The following is a description of a gene set: Genes containing one or more binding sites for (SALL4) in their promoter regions (TSS -1000,+100 bp) as identified by GTRD version 20.06 ChIP-seq harmonization. species: Homo sapiens Human Gene Set: SALL4_TARGET_GENES from publication Yevshin I, Sharipov R, Kolmykov S, Kondrakhin Y, Kolpakov F (PMID 30445619), and this is the list of marker genes: ZNF419, C1orf74, ZNF7, KPNA5, DEDD, KAT7, RAB35, ZFP91, CDK12, LRRTM4-AS1, GATAD2A, H2AZ2-DT, LINC03017, POLDIP3, SUMF1, POU2F1, UBE2Q1, SLC17A7, ZSWIM3, GABARAP, STARD5, MXD1 (NCBI Gene Id 4084), SIRT4, TRAPPC9, ZHX1-C8orf76, INTS13, HMGCR, RSBN1, TMEM30A, HDAC4-AS1, SETD5, PAIP2B, CASC3, MRPL14, SSBL4P, MGMT, SLC37A4, RMST, EFCAB6, PRADC1, R3HDM2-DT, CAMK2G (calcium/calmodulin dependent protein kinase II gamma), PDE2A-AS1, EFCAB11, DPYSL3, STRIP1 (striatin interacting protein 1), HSPA8, MORF4L2, ZNF664, ODC1-DT, SMDT1, CENPL, OTX2, SARAF, EXD1, TNFAIP1, DDX39A, ANKZF1, HEXIM2-AS1, PAFAH2, ITPRID1, CRYZL1, UBIAD1, DHX32, ABCF3, KAZALD1, FBXO3 (NCBI Gene Id 26273), PARP1, TMEM63B, LRP6, TEPSIN, ZNF687, HEY2-AS1, ANKRD16, SERTAD3-AS1, PMS2, PRPF31, OCA2, LACTB2, SKA3, RPS6KA5, LATS1, ANK3, CER1, NUBP2, ZNF280D, ACADSB, KDM4A, BTBD10, RABEP1, MIR4479, IRGQ, UHRF2, TNRC6B, ABCB8, R3HDM2, FAAP24, ZNF277, CHMP4B, ALDH6A1, CCDC86, PUF60, LRRTM3, RNF5, KDM4B, ZDHHC14, METTL13, KCTD13, ZNF8, G3BP1, STKLD1, ATOH1, TRMT1L, VKORC1L1, DUS3L, DEDD2, AK2, TMEM104, AHCYL2, PCGF3, MAU2, PRDX1, COTL1, TRIM22, STARD9, UBE2I (NCBI Gene Id 7329), TAOK3, HIF1A, MRPL45P2, HBS1L, CCT8, FHL1P1, CFAP20, GNL1, TCAF1, HSPD1, OGT, DCLK1, TRIP12, ZW10, PAXIP1-AS2, CAPZA2, DNAJB5, RHOF, SLC25A26, RPL10A, RPS11, MIR933, ZNF141, GASK1B-AS1, ZFR2, CNOT1, ANKRD30A, SNRNP70, ELL2, PIERCE2, TIPARP, MVD, CYP1B1-AS1, CYP51A1, LARP4, SAMD4A, STRN, USP2, KMT2A, CCT7, PPFIA3, DRC3, LIN37, UFSP1, ZNF808, CYB5AP2, PDE12, TTC41P, YIF1B, ZNF77, ATG9A, FGFR1OP2, PRR3, MIR3681HG, BRD2, TMEM14B-DT, C2orf42, RPLP0, DNAJC11, PFKFB4, CARNMT1, GPBP1, AGPAT1, ENPP4, HPAT5, MIR320C1, ARID2, ATF3, GPR108, CENPJ, FAM220A, ATP6V1D, SLC15A2, ALKBH7, GATB, TRAF3IP1, SUPT5H, EZR, CNPY3, COPB2-DT, ZNF337, ZNF518A, BANCR, RTF1, CLP1, TCF3, MGRN1, HINFP, CNP, MFF, GATAD2B, MRPL37, SBDSP1, CACTIN, AZI2, EPHA7, ATP11B-DT, STX1A, STK19, PPP1R12B, SIRT2, GGA3, MOBP, ENSG00000265055, PHLPP1, SNORD26, CCSER2, AASS, RPS6KB1, CTNNB1 (catenin beta 1), TRNAU1AP, NCOA4, BUD23, FAM98A, TOB1-AS1, VIRMA-DT, DET1, OSBP, SPSB3, NRDE2, ENSG00000256969, C8orf88, HELB, ISOC2, RPEP1, MYO1B, CDH13-AS2, FBXO36, RPH3A, TRIB1, PGAM1, ERI1, AGBL5, TOLLIP-DT, AJUBA-DT, ACOT13, LINC02511, NR3C2, RNU5E-6P, MYO10, FANCA, RPL35AP10, RGL1, ENSG00000255647, SLC39A7, ZFP14, INTS4, KLHL28, RPL10P15, ENSG00000241525 (novel transcript, antisense to C17orf97), ATXN2-AS, ABCC5, GRPEL1, CDC42, MTHFD2P1, PIAS4, XRCC3, PPP5C, LINC02233, PGM2L1, RPS26, SUGP1 (SURP and G-patch domain containing 1), TRIM71, CHRAC1, KHDRBS1, CHAF1A, POLA2, CEMP1, PSIP1, ISCU, ATPAF2, GASK1B, RNVU1-22, FAM136A, COX11 (NCBI Gene Id 1354), MIGA2, IQCD, KBTBD6, CBX1, GBA1LP, SERTAD2, VWA8, STXBP4, EHBP1, STYX, ZBTB7A, TENM2, FGFRL1, EDRF1 (erythroid differentiation regulatory factor 1), FOXN2, DGLUCY, PPRC1, CPNE3, KREMEN1, BAG1, SLFN12, PLXNC1, SEC24C, ZZZ3, EZH1, TSC1, SCAF11, RPS7P3, PARP10, GRB2, PPP2R5B, LINC00467 (long intergenic non-protein coding RNA 467), TMEM30A-DT, SERPINB9P1, BACH2, OSER1, C2CD2, KDM2A, CDKL3, RNF181, LAMTOR2, POT1-AS1, ENSG00000236106, LINC02614, EIF5B, PUM1, AP2S1, COPG1, YJU2, CCAR2, MEF2A, PEMT, DZANK1, SRSF10, ATXN1L, SLC15A4, DCAF16, HNRNPA3P8, CALD1 (NCBI Gene Id 800), DCAF13, CHTOP, TASOR2, OSER1-DT, HEATR5B, MLLT1, PAN3-AS1, TATDN3, INPP5F, STX18-AS1, RPL13AP26, METTL15, CCDC174, BCKDHB, LINC01551, ZNF25, BNIP3, NPM1, ATF2, SMAD3, PAXBP1, PLEKHB2, UBE2C, FDPS, STIP1, SMIM10L2B, GMPPA, PPP1R11, DOCK4, CDC16, ANKRD11, TMEM209, PAOX, RPL27, CEP295, KHK, LINC01508, UBB, EEF1A1, ZHX1, LINC01719, DNAJC17, CCDC88C, ACVR1, PAN3, PPM1K-DT, TNKS1BP1, GOT2, ZMYND8, NAMPT, LSS, CIAO2A, ZNF292, AGFG2, ZNF689, RBM4B, C4orf46, MADCAM1, ABI2, STYXL1, WDR36, ATP5MC1, WDR81, HSPE1-MOB4, XRCC2, TMEM60, IL23A, MT-CO3, IFT20, FILIP1, ZNF692, TMEM160, ENSG00000259704, TAX1BP3, COPB2, H2BC14, CEP350, PRR13, PCED1B, HSPB6, SHARPIN, PRPF39-DT, KIF18A, ACTN4, TASOR (NCBI Gene Id 51687), TUFM, USP2-AS1, NAT9, CENPX, CHCHD3, SEC31A, PPP2R5E, RAB4B, CYP2AC1P, RBPJ, TMEM143, ENSG00000187186, ARFGAP3, SLC11A2, SNX12, ZNF224, KLF6, TMED7-TICAM2, SLC39A3, WDR20, HMGCS1, ZNF112, EMG1, PJA2, AFTPH-DT, MEIS2, TNC (tenascin C), TFAP2A, CDK5, CHN2, NRL, RPIA, USP37, NANP, MALAT1, KCTD10, ABHD11, N6AMT1, UNC79, FOXA3, RPL21P112, RANBP2, SEPTIN2, TCFL5, ACOX3, CIAO1, TLE6, PCMTD1, ZNF285, ORMDL3, SKIC3, WIPI2, RAD51AP2, RAB4A, MOV10, DHX40, NSA2P4, SYMPK, EIF2AK3-DT, TMCO1-AS1 (TMCO1 antisense RNA 1), GSPT2, FAM230G, PDE6D, BCAS3, RPLP2P1, FERMT2, ITSN1, ZNF318, CCDC88C-DT, SLC19A2, GMCL1, GTF3C2-AS2, BANP, MMUT, TMED7, GABPB1-AS1, LRP3, TAS2R14, RANBP3, MIR3688-2, CFAP119, TIPARP-AS1, EBNA1BP2, PCAT6, ENSG00000233230, CAMTA1, SNORD25, UTP11, PPWD1, NME1-NME2, C6orf89 (NCBI Gene Id 221477), FBXO46, CRLS1, CDC37L1-DT, NOL7, RAB5C, SLC7A6OS (solute carrier family 7 member 6 opposite strand), KCTD9, FZR1, PSMA3-AS1, PROSER3, ULK1, IFT81, HDGF, USP30, CERS5, HUS1, KYAT3, ARL3, RAI14, CANX, SSNA1, LEPR, TMEM38A, MTMR12, LIAT1, MACROD2, ZSCAN22, KHSRP, ITGA9-AS1, LRRC27, LINC00471, LSG1 (large 60S subunit nuclear export GTPase 1), GTF2IP20, MAN1B1, RBSN, DDI2, PSMD2, RBL1, IVD, TICRR, FH, ZMIZ1-AS1, TXNDC9, LARP7, GID8, TMEM127, TUBB4B, SPG7, KDM5C, ZSWIM6, ZMIZ1, TSEN54, HSP90AA1, DOP1B (NCBI Gene Id 9980), MORC2, ENSG00000232876, LAMB1, PCYOX1, PPP2R3A, KCTD21-AS1, TBC1D9, SLC4A2, RBX1, TC2N, HSPBAP1, FAM86JP, ENSG00000275740, SUMF2, PGAP4, WIPI1, NSL1, PPARD (NCBI Gene Id 5467), MCMBP, POLR3G, PALS2, SEL1L, RACGAP1, HDLBP, UFD1-AS1, MT-TP, RANBP6, ZNF451, ARHGEF12, CFAP251, TMEM70, WAPL-DT, FDFT1, GOLGA7 (golgin A7), LINC01275, POLR2E, RAB40B, EIF2B3, TUBGCP5, USO1, EFHC1, ZNF888 (NCBI Gene Id 388559), EXOC5, NDUFV1, LIX1, G3BP2, PSMD14-DT, MIR3180-5, STX18, IBTK, RANBP1, CCDC61, NQO2-AS1, SECISBP2, STAP2, VPS26A, RPL4, NAPA, INO80B-WBP1, GNAI2, CCDC77, MPV17L2, PSENEN, EML1, WDCP, FAM86KP, SLC22A31 (solute carrier family 22 member 31), AMZ2, MED26, LMAN2, CIC, VAPB, LSM14B, NUDC, VMP1, CCNG1, DHX34, IKZF5, KBTBD6-DT, HMG20B, OSBPL1A, C1orf159, SPC25, TCF12, H2BC5, RNF32, NCOA2, PRXL2B, ACAD8, FBXL9P, SYPL1, C22orf39, PSMA3, SPRYD3, TJP2, PHF21A, REST, HSP90AB1, TENM3-AS1, HEXIM2, ELL, RNU6-92P, ZC3H6, PSAT1, ZNF286A-TBC1D26 (ZNF286A-TBC1D26 readthrough (NMD candidate)), SNORD27, PPFIA4, ENSG00000235979, CYB5RL, CLTC, BORCS8-MEF2B, RPL23AP11, PPP3CB-AS1, KMT5B, TSPAN31, WDPCP, PSME3IP1, PAM16, KLHDC3, NUP42, RXYLT1, DGKQ, ZNF83, GINM1, INTS9, H2BC16P, TNRC6C, TAOK2, SOX2-OT, FRG1CP, PPP1CA, STX2, TP53BP1, GABRB3, LTBP4, MDH2, WHAMM, DENR, NGLY1, RBM12B-DT (RBM12B divergent transcript), ZRANB2-DT, PCGF3-AS1, RBMXL1 (RBMX like 1), C15orf40, CHD9, PPP4R3B-DT, PITX2, AKT1S1, RBM27, ACLY, AP5M1, OXSM, ASPH, GPN3, RAP2A, SNHG1, GTF3C2 (NCBI Gene Id 2976), LINC00862, MKRN1, SPAG9, TXNDC11, SRRT, ELMO1, TRMT44, THYN1, ADPGK, SUMO1, RNF130, C1D, SAP30, CRTC1, FKBP3, TMCC1, MTG1, MIR548AW, EPCIP-AS1, PIM1, GSR, NUAK1, TMEM65, STK32C, PPM1N, EP400P1, OCIAD1, MRPL44, TESK2, GTF2I, PANK2-AS1, GRK4, PARD3, MIEF1, ZNF256, CBX5, UVSSA, ZNF337-AS1, PIPOX, AGBL5-AS1 (NCBI Gene Id 100874031), RPAP2P1 (RNA polymerase II associated protein 2 pseudogene 1), DNAJC30, PPCDC, TXNIP (thioredoxin interacting protein), RBPMS, FAM118A (family with sequence similarity 118 member A), GPRC5D-AS1, NDUFA5, UNC80, ABT1, CYP51A1-AS1, PAM, CHP1, PGP, INO80B, WDR47, HMBOX1, RPL36, ZNF225, EXOSC5, BCL7C, ALG8, PRR16, CENPF, AJUBA, RAB6A, DBP, ARID4A, LINC01484 (long intergenic non-protein coding RNA 1484), TOB2, ARMH4, RN7SKP175, FBXO3-DT, MPND, EIF3D, FGFR3, TAF5, MAN1B1-DT, USF3, ZCCHC24, TRAFD1, SELENOP, RXRB, XPO7, CANT1, E2F6, MIR3678, LURAP1L-AS1, BRPF1, PRKACA, SH3GL1, SNHG10, SACM1L, RIBC2, ORMDL2, ATP11B, PSMG4, CDC37L1, ZNF140, TBC1D10B, IMP3, SLCO5A1, PELI1, PTPN23-DT, SIL1, NFX1, PRMT5, RBM15B, STT3A, DHDDS, BORCS8, GM2A, RND2, ANK2, CASC2, NUP93, UBC, CDC5L, C19orf44, TDP2, LARS2-AS1, IST1, PTPRS, MIR9-2HG, UBR5, RBM15, MAD2L2 (NCBI Gene Id 10459), TMEM218, LINC01870, EXPH5, CMC1, SLC35F5, RNH1, SFXN2, RNF6, LINC01060, ATP5ME, TDRKH-AS1, FOXK1, LINC00674, ERICH2-DT, TUBA1B-AS1, WTAP, RPL24, EVI5L, SULF1, ZCCHC7, NKIRAS1, MORC3, SAP30-DT, MIR4757, TTLL7, RERGL (RERG like), FLAD1, TSSC4, CEP95, PLAC9, H2AC14, FBXL12, SF3B1, TIMM9, HSD11B1L, GOLGA5, RNF40, ZNF564, LACTB2-AS1, ZNF567, MBTPS1, RN7SKP38, ADGRL2, VPS51, RPL23AP33, ENSA (NCBI Gene Id 51620), ZNF888-AS1, MTNAP1, SORBS2, LINC01237, ZNF576, RSPRY1, ASXL1, TCEANC2, AFTPH, RIDA, NXN, FRYL, MT-TF, MIR7515HG, MFF-DT (NCBI Gene Id 654841), RRP12 (NCBI Gene Id 95039), DDA1, ERO1B, RNF32-DT, PJVK, WAPL, ZFYVE19, KDM5A, NUP107, EIF2AK3, UBE2B, TOR1AIP1, HOXC13, LRRC45, PPP6R1, DCAF1, DDX19B, LINC02453, TMC3-AS1, TMEM43, KLLN, TMEM41B, HIVEP1, ZWILCH, PTPN4, ETV5, ZKSCAN2, LINC01089, ELMO2 (engulfment and cell motility 2), CDC6, PPP4R4, VCP, TMEM94, TPCN1, VIRMA, PKM, NEMP1, NDEL1, CDH10, RNPC3, CDK5RAP3, ELF2, RANBP3-DT, RPS19, IPMK, POT1, ZNF280C, SRP19, IFT27, RAB4A-AS1, NOP14, CALM2, CCNF (cyclin F), NCAPG, NFKBIB, GLRX5, GLO1, EBAG9, CCNG2, SOX5, PPTC7, CHMP7, STK25, ZNF611, TDRKH, PDIA5, KIF2A, ETFDH, PKD1, FXR2, C19orf38, CENPK, DISC1, NQO2, MYH9, SEL1L2, JAG1, HAUS3, EFCAB6-DT, MT-TT, RFX2, PRR14L, SYNGR4, UBP1, NFE2L1, ZNF37A (NCBI Gene Id 7587), EIF2S2, GPBP1L1, HIRA, ERMN, GABPB1, TFCP2, RPS6KB2, PGBD4, TTI2, DXO, ANP32E, RNA5SP198, LARS1, APOLD1, ERRFI1, LINC02408 (long intergenic non-protein coding RNA 2408), RNGTT, UBR2, ZDHHC5, MCM3AP-AS1, KATNB1, OGA, ZNF37BP, DUSP6, TRIB1AL, AFP, HP1BP3, KCTD2, TMEM263-DT, ARRDC4, TMEM263, ERAP1, ACOT8, RELL1, MON2, CENPU, KIAA1586, WBP2, DLD, EVL, SPAG7, IREB2, OTX1, MT-RNR1, MIR5188, RSRP1, NUP153, ERGIC2, MIR6089, MIR302C, ZNF527, SEH1L, RAPGEF2, UTP3, NAA35 (N-alpha-acetyltransferase 35, NatC auxiliary subunit), TAF12, DNM2 (NCBI Gene Id 338330), VPS37D, ULK2, ENSG00000261335, EBLN3P, EIF2B1, DNPEP-AS1, CDK2AP2, BCL2L2-PABPN1, THAP9-AS1, ANKHD1, RRP1, CCDC88A, NEK3 (NIMA related kinase 3), ZC3H3, ATP5PD, RAD51B, H3-3B, EMC6, MAD1L1, LINC02570, SPRTN, CDKN2D, SEPTIN7P13 (NCBI Gene Id 84344), TENT5C-DT (TENT5C divergent transcript), PRKRIP1, VPS29, RNU4-2, SMC4, RNVU1-19, RSL24D1, EHD1, SLC8A1-AS1, FBXL19, HDAC9, DPPA4, RNF111, HNRNPC (NCBI Gene Id 3183), TMBIM6, INPP5A, SLC41A3 (solute carrier family 41 member 3), ZNF286A (zinc finger protein 286A), NOC3L, NME1, ENAH, POLG2, NAMPT-AS1, NCOA5, FRA10AC1, CENPQ (NCBI Gene Id 55166), SPRED1, PDE7A, VHL, COL18A1 (collagen type XVIII alpha 1 chain), RRM2B, OSBPL9, PAN2, SSR3, TMCC3, MIR302CHG, RINL, EMD, CITED4, IFT80, PPP1R16B, MYADM, SP5, FOXK2, KCTD13-DT, PRPF39, MRPL57, PACRG, RPL27A, TOM1L2, HDAC2-AS2, ODAD4, ZNF184, DLGAP1-AS2, HIBADH, EIF4A3, CCDC92, EPS15L1, DICER1, MIR1245B, PTTG1IP, BLOC1S5-TXNDC5 (BLOC1S5-TXNDC5 readthrough (NMD candidate)), PRKRA (NCBI Gene Id 94716), IFIT3, SCAF4, INO80D-AS1, PCCA, MRPL55, TEDC1, P4HB, CDIP1, XAB2, ACSL1, TXNRD2, TAF12-DT, CALCOCO1, TULP3, PTPN23, TMED1, RAB43, SRFBP1, PGRMC2, DDX27, NUMB, PKNOX1, RFX1, CCNB2, ANAPC5, LSM14A, BTF3, SURF4, HMG20A, ICMT-DT, ZNF335, ANP32A, RBM15-AS1, ATP5F1B, PHF12, TOMM40, SERTAD3, PNRC1 (NCBI Gene Id 10957), EPHA6, AKTIP, CEP83-DT, ZFYVE26, BMAL1, CAND1, QRICH1, MRPS16, TCERG1, ASB7, NUDCD1, MAGI1, SOX6, LINC02960, MIR638, ABHD5, FAF2, EIF4A2, SLC3A2, PPP3CB, MIR4470 (NCBI Gene Id 100616484), FAM135A, MIA3, MMD, TPM1, TMEM115, KHDC4, SLCO5A1-AS1, AARS1, DDX23 (NCBI Gene Id 9416), GBA1, MAZ, ARF1, SNRPC, ELP3 (NCBI Gene Id 55140), HESX1, ZNF567-DT, BSDC1, DAAM1, CTNND2, SPAST, TTC7B-AS1, ZNF687-AS1, FOXRED2, RMND1, ERRFI1-DT, AUTS2, SDR39U1, PA2G4, RN7SL810P, ARFIP1, PEAK1, EXOC8, TRMT2A, SEC1P, KLHL24, NEPRO, OIP5-AS1, PRDM10, PRMT7, MYO5C, CERT1, ZNF559-ZNF177, ZCWPW2, DCLRE1B, TBC1D15, NDUFAF8, MAP2K2, HNRNPDL, CNNM2, NPHP4, PLS1, LENG1, UBR5-DT, CCPG1, LINC02926, HNRNPL, RNU7-88P, RNU6-263P, SDE2, ODC1, BCL2L2, ERN1 (NCBI Gene Id 63433), MARS1, AP2M1, GFPT2 (glutamine-fructose-6-phosphate transaminase 2, NCBI Gene Id 9945), LRCH4, AK7, FAM76A, ZNF281, MTRFR, LYSMD1, AVPI1, MYPOP (Myb related transcription factor, partner of profilin), HLTF, HDAC4, FBH1, VCF1, B3GNTL1, ANKFY1, RCOR3, SMPD1, BBX, PNKD, BCO1, ACCS, XPO5, TTC21B, RSU1, KANSL2, PEX19, CD99P1, PNRC1-DT, MRPS31, CCNI, SP4, DLEU1, RAD9B, BCKDHA, ACTR3, KLF10, LRIG1, LINC02282, ARHGAP26, CUEDC2, RAB5B, CYRIB (NCBI Gene Id 51571), ESCO2, PHF23, THUMPD3-AS1, RMDN1, MRPL24 (NCBI Gene Id 79590), PEX16, MIR3190, ENY2, CBR3-AS1, ENOPH1, BRWD1, CCDC144NL-AS1, SRSF1, POLK, RBM42 (RNA binding motif protein 42), LINC01649, TRAM1, LDB2, SDHB, HDGFL2, SMIM14, ATXN2, MOB3A, KIAA0319L, GBF1, SRRM5, PUM2, SMG5, RAB4B-EGLN2, LINC01409, SND1, MYL5, LMBR1, SFI1, EIF5, H2BC6, PHIP, RIC8B, BCL2L1, NFATC2IP, ZNF692-DT, CALR3, FAM86DP, PPM1B, TRAV6, ZNF341-AS1, SNORA70, RNU6-173P, DDX5, SELENOK, HBP1, AAMP, MTHFD1, VRK3, ABCA7, CALM3, TOB1, PCBP2, ABLIM2, TECRP1, ZSCAN10, SH3BP2, PTEN, DNAJB12, MAFK, PIGF, CETN3, LETM1 (NCBI Gene Id 3954), LINC00838, ADCK5, PPP5D1P, BCL3, EML4, TIPIN, RNF43, ERCC6L2-AS1, DNLZ, PSMD5, MEPCE, THAP9, ABI1, SCAF1, SREBF2, KIZ, UBE2D3, GPC1, PCMTD1-DT, LIMD1-AS1, VPS8, HSBP1, CNKSR3, POGZ, OSR2, FMNL3, TFAP4, MDM4, NAV2, TMEM79, LRATD2, ZNF106, UGGT2, ARMH3, CALU, EGLN3, FRAT2, OBSL1, ZNF25-DT (NCBI Gene Id 105376499), ETV4, PDK1, TUBGCP3, SLC38A4-AS1, TGIF1, EIF3E, TTLL12, ZC3H14, RETREG3, CHST12, PEX10, EDRF1-DT, PDE2A, MICOS13, EIF4ENIF1, AP1G1, BLOC1S5, C19orf73, PRKN, NLK, FRMD5, UQCRC1, TMCO1, H2AZ2, AFG3L2, H2BC4, IZUMO4, PFKFB2, RPL15, ERCC6L2, SLC7A11, LINC02901 (long intergenic non-protein coding RNA 2901), OSBPL2, LRRTM4, PET100, CNOT9, ACTL6A, RMDN3, CDK4, IQGAP1, CDC42SE1 (CDC42 small effector 1), MTMR4, ANKHD1-DT, TCF19, RGS5, DARS2 (aspartyl-tRNA synthetase 2, mitochondrial), PHB2, AIRIM, NELFB, GPRC5B, LINC01013, ANAPC2, FAM117A, MDC1, KLHL26, LINC01124, CP, MIR3178, NOLC1, SH2B1, ZFP91-CNTF, CCHCR1, ZNF816-ZNF321P, NAPB, SMG1P3, MIR548AL, GPAA1, RAB3A, LSM4, ARMT1, PELP1-DT, MRTFA, TIAM2, UBQLN4, LAMTOR3, NPTN, PDE7A-DT, KANSL3, TCF4, FGFR2, ENSG00000272008, ZCCHC8, H2AC16, ASNS, SNHG16, SMNDC1, GNB2, MTND6P17, SP1, DICER1-AS1, RNF126, METTL2B, LMCD1-AS1 (NCBI Gene Id 401050), AP3S2, GFI1B, LRRC28, SYNPO2, SREBF1, SNX1, PRR11, ENSG00000206853, ZNF526, USP36, NUDT16-DT, SEC23IP, TMEM14B (NCBI Gene Id 81853), CLASP1 (cytoplasmic linker associated protein 1), AKAP11, PCNX3, BIRC5, LINC01320, FOXJ3 (forkhead box J3), PDP2, ZFYVE27, DCAF11, LIN52, TOLLIP, POLH, DNAJB5-DT, NCBP1, GOLT1B (NCBI Gene Id 51026), ZBTB20, RBM12B, PLD6, CT66, EMC7 (NCBI Gene Id 56851), TMEM69, GTPBP1, SLC49A4, SARNP, CAV1, TUBD1, PXN-AS1, KBTBD7, RAB1A, HEXIM1, SNAI3-AS1, FASTKD1, NCDN (NCBI Gene Id 23154), ZNF816, MSMO1, MARS2, STEAP2-AS1, USP3, ZFYVE21 (zinc finger FYVE-type containing 21), NIPA2, ZNF225-AS1, MIR22HG, MATR3, SP2, MIR3912, ANGPT1, EHF, PRH1, MPHOSPH9, PPP4R3B, DIDO1, MIR302D, SNHG21, MEA1, LUC7L2, ASNSD1, MCOLN1, RBM47 (NCBI Gene Id 54502), CHCHD4, CCNE2, PPM1K, MORF4L2-AS1, DSN1, ITGB8, COPS7B, POFUT2, SCNM1, CALM1, UBE2D3-AS1, LMCD1, ATAD2, PMEL, RAP2B, GABPB2, CYTH2, TBC1D17, TRA2B, RTN2, VRK1, CDCA2, PPAT (phosphoribosyl pyrophosphate amidotransferase), E2F3, FANCM, DLEU2, TOP2A, RNF227, LEPROT, AIMP2, ZDHHC24, FAM83D, PTDSS2, TTBK2, GPI, ACAD9, PI4K2A, TMEM52, SEC62, SLC25A25, PANK2 (pantothenate kinase 2), DMXL1 (Dmx like 1), MTMR14, HNRNPUL1, STAT2, NAIF1, MIS18A, DCAF7, MIR367, RNF34, MEGF8, EIF2S1 (NCBI Gene Id 1965), ENSG00000260958, FBXO24, SLC7A5P2, HHAT, ZSWIM4, RPL31P40, HSPD1P18, CASKIN2, TDP1, TENT5C, STX17, TMEM14C, FDXR, MRPS7, COPS6, VPS28, WWC2, CAMTA1-DT, RECQL, ARSK, TTC23, TRIP10, SCARNA2, STK17A, MACIR, MYH9-DT, FBXL3, GPATCH11, SMARCA4, PLCD1 (phospholipase C delta 1), FOXP1, RPL26, ICMT, AKAP8L, SLC25A42, RAC1, KDM3A, ENSG00000273162, EFCAB13, DNPEP, FBXL5, TOMM34, SEPTIN9, BTRC, RFXANK, TMEM44-AS1, MTCH2, FAM86FP, HECW1, BNAT1, ATF4, LEO1, TMEM208, ATF7IP, CRIPT, TSACC, TUBA1B, NOB1, LDLRAD3, OSBPL10, ZNF219, ING1 (inhibitor of growth family member 1), SKA2, PELP1, SSR1 (signal sequence receptor subunit 1), ISLR2, RASAL2-AS1, PHTF2, ZNF8-ERVK3-1, ENSG00000267248, PPP1CC, ATXN2L, GID4, XKR9, EIF4E3, SMIM7, CISD1, HOXD8, MIR512-2, AKAP10, RYR3, TCF7L2, HNRNPA1, DCUN1D4, POP1, DPYSL2, HIP1, PFN2, CNOT3, HSP90B1, CHMP5, KCNAB2, ZNF821, LINC01333, ZNF321P, RNU2-17P, MCM8-AS1, PHLDB2, TRAF2 (NCBI Gene Id 7186), NUP107-DT, MAF1, ATP6V1C1, C6orf141, U2AF1L4, MBTPS1-DT, TFPT, SGTA, FAM200B (NCBI Gene Id 285550), GRINA, LPXN (NCBI Gene Id 9404), RAB35-AS1, SLC25A32, ZBTB38, CEP83 (NCBI Gene Id 51134), MYL11, CLTCL1, MAP3K11, MTF2 (metal response element binding transcription factor 2), RNF19A, ZNF8-DT, CLEC16A, CCDC150, MTR, ZFTRAF1, COX7A2, YOD1, FAM169A, FBXO11, RPL8, ZNF559, OSCP1, ARPC5 (NCBI Gene Id 10092), EFCAB13-DT, ZNF764, KCNIP2-AS1, STAU1, B3GALNT2, TMEM59 (NCBI Gene Id 9528), SMIM14-DT, DESI2, RBM39, STXBP3, GTF2H3, H2AC6, SHKBP1, YAP1P3, KIAA0586, CHPF, ZNF555, ST3GAL1, CEP131, TOGARAM1, SLU7, NDUFV1-DT, SUSD6, NDUFAF4, PLBD2, EDEM1, SNX8, RPRD1A, RNPC3-DT, LAMP1, UBE2D2, LRFN5-DT, EIF4A1, ADIPOR1, MFAP3L, TMEM18, EVI5, DMXL2, SIVA1, RASAL2, NR2C1 (nuclear receptor subfamily 2 group C member 1), XRCC5, PRR4, GSPT1, MT-ATP6 (NCBI Gene Id 4508), PRCC, ANKHD1-EIF4EBP3, ZNF473, RFLNA, GZF1, RBM25, HSPE1, CCT3, ARF3, TMEM198, GOLGB1, SFPQ, MIR302A, FAM216A, TSC22D1, ACTN3, LINC02693, LINS1, ABHD2 (NCBI Gene Id 654057), ATL3, RAP1A, ZNF3, SMC1B, ENSG00000275765, PHF20L1, ATG2A, ZNF616, AP4B1, HEY2, NUDT16 (nudix hydrolase 16), TUBG1, SLC35B3 (solute carrier family 35 member B3), MDH1, JUP, ZMYM4, NTAQ1, CEP89, POLN, RAD18